Given this list of marker genes CASP1, NLRP3, PANX1, NFKB2, MEFV, P2RX7, RELA, NFKB1, TXN, SUGT1, HSP90AB1, APP, TXNIP, PYCARD, PSTPIP1, HMOX1, here is a description of the gene set: The NLRP3 inflammasome Human Gene Set: REACTOME_THE_NLRP3_INFLAMMASOME species: Homo sapiens